Given this list of marker genes ORC1, C17orf58, KCTD3, L3MBTL2, DAAM1, DDX11, ZNF367, EPB41L1, ARID1A, HOXA10, EBF3, RBL1, NR2F2, THUMPD3, HOXB7, FDX1, FAM83C, SLITRK6, MN1, MTRFR, TACC2, ANAPC10, ZNF395, KBTBD6, ERF, WDHD1, ZNRF3, KCTD15, GPR39, THBS1, SRGAP3, PHLPP1, MAP3K5, RASL11B, CEP44, ZNF451, DACH1, USP1, RHOB, SIM2 (NCBI Gene Id 6493), DYNC2I1, RFX7, ITFG1, GRHL2, TPRG1, GPCPD1, IFFO2, MCM10, ADAMTS1 (ADAM metallopeptidase with thrombospondin type 1 motif 1), RTN4IP1 (NCBI Gene Id 84816), TMEM201, PDXP, E2F2 (NCBI Gene Id 1870), CCNE2, TMEM17, ATF2, BCOR, RAB11FIP2, ZIC2, DNMT3B, CCDC51, SMC3, C4orf19, GCNT1, SSX2IP, NUMA1 (nuclear mitotic apparatus protein 1, NCBI Gene Id 4926), NDUFV3, GIT2, SMAD6, DTL, TMEM131L, ZNF362, NADK2, EFCAB7, C1GALT1, MPHOSPH9 (M-phase phosphoprotein 9, NCBI Gene Id 64797), LRRC17, BDNF, CEP85, CSTF2T, DLEU1, C2orf74-AS1, LGR4, LFNG (NCBI Gene Id 3955), PTHLH, DPH5-DT, ADAMTS15, DLG3, DAPK1, RHOBTB2, MSH6, ARRDC3, B3GALNT1, ABHD10, AUTS2, FBXL16, GGA2, KANK1, DCLRE1A, NFIA, RFC4, SYTL5, TMEM53, SEPTIN7, MTUS1, CEP170, here is a description of the gene set: species: Homo sapiens Tumor necrosis factor alpha (TNFalpha) has been used to treat patients with certain tumor types. However, its antitumor activity has been undermined by the activation of IkappaBalpha kinase (IKK), which in turn activates nuclear factor-kappaB (NF-kappaB) to help cancer cells survive. Therefore, inhibition of TNFalpha-induced IKK activity with specific IKK inhibitor represents an attractive strategy to treat cancer patients. This study reveals IKI-1 as a potent small molecule inhibitor of IKKalpha and IKKbeta, which effectively blocked TNFalpha-mediated IKK activation and subsequent NF-kappaB activity. Using gene profiling analysis, we show that IKI-1 blocked most of the TNFalpha-mediated mRNA expression, including many genes that play important roles in cell survival. We further show that in vitro and in vivo combination of TNFalpha with IKI-1 had superior potency than either agent alone. This increased potency was due primarily to the increased apoptosis in the presence of both TNFalpha and IKI-1. Additionally, IKKbeta small interfering RNA transfected cells were more sensitive to the treatment of TNFalpha. The study suggests that the limited efficacy of TNFalpha in cancer treatment was due in part to the activation of NF-kappaB, allowing tumor cells to escape apoptosis. Therefore, the combination of IKI-1 with TNFalpha may improve the efficacy of TNFalpha for certain tumor types. Genes down-regulated in BxPC3 cells (pancreatic cancer) after treatment with TNF or IKI-1, an inhibitor of IkappaB kinase (IKK). from publication Zhang Y, Gavriil M, Lucas J, Mandiyan S, Follettie M, Diesl V, Sum FW, Powell D, Haney S, Abraham R, Arndt K (PMID 19010928) Human Gene Set: ZHANG_RESPONSE_TO_IKK_INHIBITOR_AND_TNF_DN